Given this list of marker genes Crp, Cfhr4, Mptx1, Calr, Masp2, Cfh, Vsig4, C4a, Itgam, Cd93, Ptx3, Itgb2, Cfhr1, Cfhr2, Itgav, Phb1, Megf10, C1qbp (complement component 1, q subcomponent binding protein), Mptx2, Cr1l, Apcs, Clec7a, C4b, here is a description of the gene set: Binding to an opsonin, such as a complement component or antibody, deposited on the surface of a bacteria, virus, immune complex, or other particulate material. species: Mus musculus Mouse Gene Set: GOMF_OPSONIN_BINDING